The following is a description of a gene set: Human Gene Set: HP_REDUCED_FACTOR_XII_ACTIVITY Reduced factor XII activity studied in species Homo sapiens Decreased activity of coagulation factor XII. Factor XII (fXII) is part of the intrinsic coagulation pathway and binds to exposed collagen at site of vessel wall injury, activated by high-MW kininogen and kallikrein, thereby initiating the coagulation cascade., and this is the list of marker genes: BRAF, PTPN11, MGAT2, MAP2K1, SLC37A4, F12